Given this list of marker genes POMC, MC2R, here is a description of the gene set: The precursor peptide pro-opiomelanocortin (POMC) gives rise to many peptide hormones through cleavage. The cleavage products corticotropin (ACTH) and beta-lipotropin give rise to smaller peptides that have distinct biologic activities: alpha-melanotropin and corticotropin-like intermediate lobe peptide (CLIP) are formed from ACTH; gamma-LPH and beta-endorphin are formed from beta-LPH. ACTH (POMC(138-176) stimulates the adrenal glands to release cortisol, a glucocorticoid released in response to stress whose primary functions are to stimulate gluconeogenesis, suppress the immune system and aid metabolism of fats, proteins and carbohydrates.<br><br>Defects in ACTH can cause obesity (MIM:601665) resulting in excessive accumulation of body fat. Defects in ACTH can also cause pro-opiomelanocortinin deficiency (POMCD; MIM:609734) where affected individuals present early-onset obesity, adrenal insufficiency and red hair. studied in species Homo sapiens Reactome Pathway: Defective ACTH causes obesity and POMCD part of: Diseases of metabolism